Given this list of marker genes TRPM6, SOD2, RAI1, TP53BP1, DDX3X, ASF1A, BNC1, ANKRD12, HIF1A, TNRC6B, EMC10, SSB, ABCC3, AP3B1, PLEKHG2, ASIC3, PLXNA3, PEX5L, BICDL1, ERAP1, CCR7, HPCAL1, SNED1, FYB1, LIAT1, PARP3, CXCR5, CEP135, CACYBP, NBDY, EID1, ADCY6, PPTC7, ADAMTS16, GNL3, TERF1, ZMYND8, NFKBIZ, STX6, DDX24, SLC25A13, REEP3, RAPGEF1, CSNK1D, IKBKE, RPL7, MIGA1, RIT2, FGF2 (fibroblast growth factor 2), TMEM51, KLHDC3, SYT11 (synaptotagmin 11), ZEB1, IMPA2, RACK1, ATOSA, PDK1, AR, AGPAT5, TTC27, NFKBIA, XRCC5, MBOAT7, RASA1, TOX, PPA2 (NCBI Gene Id 92033), TTC3 (tetratricopeptide repeat domain 3), ACSL3, IFFO2, B4GALNT1, PHF20, DPP4, CCM2, FGF13, SLC6A6, PCBP3, BPGM (NCBI Gene Id 669), TIMM9, RPS8, AKAP13, SPOCK2, TESC, ATP13A4, ARMCX2, EZH1, FRMD4A, TRIB2, FAM53B, ICA1L, WHRN (whirlin), KCNMB2, ZMAT4, BRI3BP, FERMT2, HSDL1, ZNF365, PAQR7, ICOS, TMEM238L, MAP9, PRPS2, TSHZ2, SENP8, RPA1, OPTN, ACE2, TMEM158, TGFBR2, CCDC150, QKI, MAN2C1, ASCL2, COPRS, CPLANE1, SCCPDH, CAPSL, DTD1, ZNF318 (zinc finger protein 318), PLOD2, PRPF38B, CCR10, DDIT4, PGM5, NANOS1, CDK17, DCUN1D1, CCDC125, ACYP1, PFN2, EML4, SEC63, GGA2, TBCE, NUDT6, ZNF839, LIPA, RPL39, PHF3, SLC16A8, EGLN3 (NCBI Gene Id 63900), MRPS6, PPM1A, MBOAT1, TBC1D4, TFAP4, ESCO1, SLC52A2, ZMYM5, ZNF512B, LIMD2, MIF, ZDHHC24, NMNAT3, CTDSP2, GLRB, CASP4, OXSR1, MAGED1, WASHC4 (NCBI Gene Id 23325), ELMOD3, LAMP1, CDC73, MTLN, NKRF, POLR3E, WDR46, C1orf216, DICER1, CACNA2D4, NDUFAF4, TOR1AIP2, TMEM131, PKP4, ENPP2, FXR1, TMA16, C1QBP, ANKHD1, BCL7A, ATRX, ARHGAP39, CDK19, MGST2, POLR1C, AMER1, SF3A3, JAK2, OTUD4, SHLD1, ABCG4, DAG1, CXCR3, RGS12, SESTD1, SRPK2, ZNF48, IGF1R, LINC01973, DGKZ, TGFB3, here is a description of the gene set: Human Gene Set: GSE3720_VD1_VS_VD2_GAMMADELTA_TCELL_WITH_LPS_STIM_UP from publication Kress E, Hedges JF, Jutila MA (PMID 16423401) species: Homo sapiens The two major human gd T cell subsets, Vd1 and Vd2, display differences in tissue tropism and agonist responses, but we have little insight into global differences that may exist at the gene expression level. This is due to the small numbers of these cells that can be obtained from healthy donors, which limit comprehensive, comparative gene expression analyses. We established a culture method that expands Vd1 and Vd2 cells from the same PBL preparation to levels sufficient for sorting and microarray analysis. Although the subsets were expanded identically (anti-TCR mAb, plus IL-15), 392 and genes were identified, which were differentially expressed in the two subsets, from two donors, respectively. Approximately genes changed in both subsets following PMA/ionomycin treatment; about 50% of these genes were subset-specific. Both subsets responded to a crude LPS preparation, but only 6% of the responsive genes were the same. The differentially expressed genes were consistent with Vd2 cells being more inflammatory and Vd1 cells having more of a regulatory phenotype. Both subsets expressed transcripts encoding an array of innate and NK cell receptors, supporting the relationship of gd T cells to the innate immune system. Our results show that circulating Vd1 and Vd2 subsets in humans have considerable, inherent differences in gene expression following treatment with non-TCR agonists, supporting unique functional roles for these cells in vivo. Genes up-regulated in gamma delta T cells stimulated by LPS: Vd1 versus Vd2.